Given this list of marker genes Il6ra, Cntf, Il6st, Pycard, Erap1, Il6, Adam17, here is a description of the gene set: Binding to an interleukin-6 receptor. Mouse Gene Set: GOMF_INTERLEUKIN_6_RECEPTOR_BINDING species: Mus musculus